Given this list of marker genes PPP3R1, PPP3CC, PPP3CA, NFATC2, CXCL8, PTGS2, NFATC1, GNAQ (G protein subunit alpha q), PPP3CB, PLCB1, CALM1, PLCB3 (phospholipase C beta 3), PPP3R2, NFATC3, NFATC4, CALM3 (calmodulin 3), PLCB2, CALM2, PLCB4, here is a description of the gene set: Pathway Definition from KEGG: US28 -> GNAQ -> PLCB -> IP3 -> Ca2+ -> CALM == CN -> NFAT => (CXCL8,PTGS2) studied in species Homo sapiens HCMV US28 to GNAQ-PLCB/G-calcineurin signaling pathway. Pathway ID: N00402. Pathway type: Pathogen. Pathway class: nt06167 Human cytomegalovirus (HCMV). Human Gene Set: KEGG_MEDICUS_PATHOGEN_HCMV_US28_TO_GNAQ_PLCB_G_CALCINEURIN_SIGNALING_PATHWAY